The following is a description of a gene set: A number of so called non-canonical WNT ligands have been shown to promote intracellular calcium release upon FZD binding. This beta-catenin-independent WNT pathway acts through heterotrimeric G proteins and promotes calcium release through phophoinositol signaling and activation of phosphodiesterase (PDE). Downstream effectors include the calcium/calmodulin-dependent kinase II (CaMK2) and PKC. The WNT Ca2+ pathway is important in dorsoventral polarity, convergent extension and organ formation in vertebrates and also has roles in negatively regulating 'canonical' beta-catenin-dependent transcription. Non-canonical WNT Ca2+ signaling is also implicated in inflammatory response and cancer. studied in species Homo sapiens Reactome Pathway: Ca2+ pathway part of: Beta-catenin independent WNT signaling, and this is the list of marker genes: GNG3, FZD6, TNRC6C, MYC, GNG13, TNRC6B, GNB2, PDE6A, GNB1, PPP3R1, ITPR1, GNB5, AXIN2, AGO4, GNG4 (NCBI Gene Id 2786), GNG12, PDE6B, WNT11, FZD2, GNG11, GNAO1, WNT5A, GNG5, PLCB1, PRKG2, NLK, PPP3CB, TNRC6A, GNG2, CALM1, PPP3CA, MAP3K7, GNGT2, GNB3 (G protein subunit beta 3), GNG7 (G protein subunit gamma 7), TCF7, GNG8, TCF7L1, AGO3, KRAS, MIR92b, CAMK2A, LEF1, FZD5, ITPR2, GNB4, CTNNB1, PLCB2, AGO2, TCF7L2, PDE6G, GNAT2, GNGT1, GNG10, AGO1, NFATC1, PRKCA, PRKG1, FZD4, MOV10, FZD3, ITPR3, PLCB3